Given this list of marker genes Slc1a5, Ifi202b, Ramac, Oprm1, C1qtnf12, Sbf2 (NCBI Gene Id 74581), Hras, here is a description of the gene set: We characterized differential gene expression profiles of fibroblast cell lines harboring single or double-homozygous null mutations in H-ras and N-ras. Whereas the expression level of the individual H-, N- and K-ras genes appeared unaffected by the presence or absence of the other ras loci, significant differences were observed between the expression profiles of cells missing N-ras and/or H-ras. Absence of N-ras produced much stronger effects than absence of H-ras over the profile of the cellular transcriptome. N-ras(-/-) and H-ras(-/-) fibroblasts displayed rather antagonistic expression profiles and the transcriptome of H-ras(-/-) cells was significantly closer to that of wild-type fibroblasts than to that of N-ras(-/-) cells. Classifying all differentially expressed genes into functional categories suggested specific roles for H-Ras and N-Ras. It was particularly striking in N-ras(-/-) cells the upregulation of a remarkable number of immunity-related genes, as well as of several loci involved in apoptosis. Reverse-phase protein array assays demonstrated in the same N-ras(-/-) cells the overexpression and nuclear migration of tyrosine phosphorylated signal transducer and activator of transcription 1 (Stat1) which was concomitant with transcriptional activation mediated by interferon-stimulated response elements. Significantly enhanced numbers of apoptotic cells were also detected in cultures of N-ras(-/-) cells. Our data support the notion that different Ras isoforms play functionally distinct cellular roles and indicate that N-Ras is significantly involved in immune modulation/host defense and apoptotic responses. Mouse Gene Set: CASTELLANO_HRAS_TARGETS_DN from publication Castellano E, De Las Rivas J, Guerrero C, Santos E (PMID 16909116) studied in species Mus musculus Genes down-regulated in MEF cells (embryonic fibroblast) isolated from HRAS knockout mice.